The following is a description of a gene set: Abnormality of the Leydig cells Human Gene Set: HP_ABNORMALITY_OF_THE_LEYDIG_CELLS species: Homo sapiens, and this is the list of marker genes: CYP11A1, ALMS1, GNAS, PRKAR1A, PDE11A, MRAP, SMS, MC2R, FSHB (NCBI Gene Id 2488), STAR, LHB, TXNRD2, NNT